Given this list of marker genes UPP1, DPYS, UPP2, DPYD, UPB1, here is a description of the gene set: studied in species Homo sapiens Human Gene Set: GOBP_CMP_CATABOLIC_PROCESS The chemical reactions and pathways resulting in the breakdown of CMP, cytidine monophosphate.